The following is a description of a gene set: Mouse Gene Set: GOMF_HISTONE_DEUBIQUITINASE_ACTIVITY A deubiquitinase that cleaves ubiquitin from a histone protein to which it is conjugated. studied in species Mus musculus, and this is the list of marker genes: Usp3, Bap1, Usp49, Usp36, Usp51, Usp22, Usp16, Mysm1